The following is a description of a gene set: In this study we compared the effects of IL-2, IL-15, and IL-21 on the gene expression, activation of cell signaling pathways, and functional properties of cells derived from the CD4+ cutaneous T-cell lymphoma (CTCL). Whereas both IL-2 and IL-15 that signal through receptors that share the common gamma chain and the beta chain modulated the expression of >genes, IL-21 that signals via the receptor also containing gamma chain up-regulated <genes. All three cytokines induced tyrosine phosphorylation of Jak1 and Jak3. However, only IL-2 and IL-15 strongly activated STAT5, PI3K/Akt, and MEK/ERK signaling pathways. In contrast, IL-21 selectively activated STAT3. Whereas all three cytokines protected CTCL cells from apoptosis, only IL-2 and IL-15 promoted their proliferation. The effects of the cytokine stimulation were Jak3- and Jak1-kinase dependent. These findings document the vastly different impact of IL-2 and IL-15 vs. IL-21 on malignant CD4+ T cells. They also suggest two novel therapeutic approaches to CTCL and, possibly, other CD4+ T cell lymphomas: inhibition of the Jak1/Jak3 kinase complex and, given the known strong immunostimulatory properties of IL-21 on CD8+ T, NK, and B cells, application of this cytokine to boost an immune response against malignant CD4+ T cells. Human Gene Set: GSE8685_IL15_ACT_IL2_STARVED_VS_IL21_ACT_IL2_STARVED_CD4_TCELL_DN from publication Marzec M, Halasa K, Kasprzycka M, Wysocka M, Liu X, Tobias JW, Baldwin D, Zhang Q, Odum N, Rook AH, Wasik MA (PMID 18281483) studied in species Homo sapiens Genes down-regulated in Sez-2 cells (T cell lymphoma): IL15 versus IL21., and this is the list of marker genes: CD4, CALML3, MLEC, TTC13, SMOC1, RND3, RPL19, TMEM209 (transmembrane protein 209), PDLIM5 (PDZ and LIM domain 5), RNF157, MTSS1, ADPRHL1, LRRC14, MFNG, GRAMD4, CBX4, POLR1A (RNA polymerase I subunit A), ALG6, RPS14, MAMDC4, PPARGC1B, RDH10, GAL3ST3, VPREB3, RN7SK, UTP14A, ZNF729, LYST, FEZ2, UGCG, RRS1, APPL2, SNN, SLC25A10, NFE2L2, RAD50, THEMIS, HERC3, PALS2, GALNT7, SGMS1, TCF7, ARHGEF9, MFSD2B, CD40LG, RAPGEF2, BYSL, PWP1, PIK3CG, IBTK, TNS4, ST8SIA6, NUP210, VPS37B, ARL2, PIGV, RAB20, EEF1B2, ATAD3A, IKZF1, HS6ST1, SGIP1, DNAJC3, EEIG1, PPTC7, LPIN1, EIF3I, LLPH, XKRX, IDH2, RPL32, CLASP2, TMEM71, PRPF31, PRMT5, DKC1, HEATR1, HDAC5, PCDHB17P, RPL12, CDKL1, POLR1C, SEPHS1 (NCBI Gene Id 88214), SELENOP, COQ3, TRIB2, C18orf32, ACVRL1, RFLNB, CKAP4, SULT1B1, DMBT1, DPPA2, MTFR1L, TC2N, MACO1, ATPAF1, SPP1, GPR171, TTC7B, NOP14, HS2ST1, LSG1, CHCHD3, IL17RA, CUL9, RABAC1, AICDA, TMEM115, STARD7, ADRB2, ID2, ATP5F1B, ELOVL7, DAAM1, DDX21, SLFN5, MIR299, SATB1, ZFP14, SERPINA6, AVL9, SEC16A, TIMM44, SPART, SLC38A1, KLHDC2, RPS5, SNX12, RPS3, NSA2, F2RL1, PPP4C, RPSA, GALNT13, AGGF1, CDYL2, AKT2, SMURF2, AQP9, B4GALT3, CD177, MICU1, RRP12, RIPOR2, CCDC88A, LCMT2, TSEN2, MRPL46, CIAO1, WDR88, NME4, GPD2, PCYOX1, TAF15, FNTB, GRAP2, IFIT1, PIM2, TLE4